The following is a description of a gene set: studied in species Homo sapiens Abnormal pulmonary alveolar system morphology A structural abnormality of the pulmonary acinus, alveolar parenchyma, or alveoli. Human Gene Set: HP_ABNORMAL_PULMONARY_ALVEOLAR_SYSTEM_MORPHOLOGY, and this is the list of marker genes: CAPNS1, KMT2D, FOXF1, SLC34A2, GUF1 (GTP binding elongation factor GUF1), KDM6A, SFTPC, STRA6